The following is a description of a gene set: Genes predicted to be targets of miRBase v22 microRNA hsa-miR-1262 in miRDB v6.0 with MirTarget v4 prediction scores > 80 (high confidence targets). from publication Chen Y, Wang X (PMID 31504780) studied in species Homo sapiens Human Gene Set: MIR1262, and this is the list of marker genes: MSRB2, MPDU1, ETFRF1, OCM2, QKI, CAMK2D, OCM, NTS (neurotensin), TNPO3, RAB27B, DUOX1, ZNHIT1, BEST1, PRPF38B, SALL3, GLYATL2, DOCK7, HDGF (NCBI Gene Id 92300), OSBPL1A (NCBI Gene Id 55097), TBX5, SLC35E2A, DHFR, CMTR1, IQSEC2, RPE, CD37, C6orf89, ZNF607, GEMIN5, PHLDB2, ZCCHC17, SUOX, USP14, ADH6, YIPF1, HSD17B4, LIPA, SLC66A1LP, TMEM100, TYRO3, FGFR1, CRNKL1, NRG3, FLI1, KSR2, MFAP5, EXOC3L2, EPM2A, SPTBN1